The following is a description of a gene set: Human Gene Set: HP_BLADDER_NEOPLASM Bladder neoplasm The presence of a neoplasm of the urinary bladder. species: Homo sapiens, and this is the list of marker genes: NTHL1, NRAS, APC, HRAS, PIK3CA, BUB1, SRC, PLA2G2A, TP53 (tumor protein p53), PDGFRL, FLCN, RB1, ATP7A, RAD54B, PTEN, MCC, MLH3, AURKA, EP300, DLC1, CCND1, DCC, CTNNB1, AXIN2, TLR2, AKT1, PTPN12, RNF43, BRAF, PTPRJ, BUB1B, BAX, KRAS, FGFR3